Given this list of marker genes Ypel2, Cacna1a, Gpd2, Cldn2, Tbc1d14, Stag2, Slc16a6, Saysd1, Ppp1cb, Plekha3, G3bp2, Bicd1, Adam1b, Fbxo33, Aplnr, Zfx, Pcyt1a, Mef2a, Deptor, Htr2c, Mapkapk3, Cdh11, Tob1, Sox8, Ptger2, Clec2e, Il6st, Synpo2, Erc2, Phex, Hif3a (hypoxia inducible factor 3, alpha subunit), Pld1, Pan3, Ctdspl2, Sdhc, Grip1, Map3k20, Enpp4, Pi4k2a, Map1a, Slc35d2, Ppm1g, Mgat3, Creg2, Nus1, Ube2q1, Rsrc2, Vcp, Sumo2, Pou3f4, Zfp951, Tor1b, Sod2, Mmp14, Cadm2, Tnfsf8 (NCBI Gene Id 21949), Foxred2, Csnk1e, Scn8a, Ereg, Zyg11b, Pcdh20, Anln, Rps6kb1, Syt1, Zcchc14, Otc, Agps, Zfp36l1, Pla2g6, Sacs, Zic4, B230219D22Rik, Kmt5a, Zc2hc1a, Hoxb4, Irx1, Zmiz1, Sertm1, Epha7 (Eph receptor A7), Fgf11, Prtg, Gm9, Npc1, Mbnl1, Man1a, Ctbp1, Napa, Rbm47, Pnrc2, Gpr158, Hycc2 (hyccin PI4KA lipid kinase complex subunit 2), Lrat, Ssbp3, Unc5c (NCBI Gene Id 99539), Sec24b, Ablim3, Stxbp6, Phf20, Esrrg, Kdm5c, Mblac2, Chpt1 (choline phosphotransferase 1), Spast, Prdm8, Slc24a2, Pde3a, Cul2, Sypl2, Zc3h6, Mslnl, Ube2j1, Ifi213, Lpp, Aard, Ascl4, Arrb1, Baz2b, Layn, Tab2, Amot, Arid1a, Cyp4a31, Slc7a6, Mapt, Pbrm1, Tra2a, Aff4, Cept1, Pafah1b1, Hspb7, Zfp91, here is a description of the gene set: from publication Chen Y, Wang X (PMID 31504780) Mouse Gene Set: MIR_7238_3P species: Mus musculus Genes predicted to be targets of miRBase v22 microRNA mmu_miR_7238_3p in miRDB v6.0 with MirTarget v4 prediction scores > 80 (high confidence targets).